The following is a description of a gene set: Human Gene Set: HP_DISPROPORTIONATE_SHORT_TRUNK_SHORT_STATURE A type of disproportionate short stature characterized by a short trunk but a average-sized limbs. species: Homo sapiens Disproportionate short-trunk short stature, and this is the list of marker genes: MESP2, GLB1, FN1, BGN, BMPER, DLL3, FLNB, PUF60, CFAP410, ARSK, RAB33B, COL2A1, DYM, TRIP11, ARSB, GALNS, XYLT2, TRPV4, TBX6, TRAPPC2, CCN6, BRF1, ACP5 (acid phosphatase 5, tartrate resistant), NKX3-2, CHST3, RSPRY1, KIF22, SMARCAL1